The following is a description of a gene set: species: Homo sapiens from publication Menon R, Otto EA, Kokoruda A, Zhou J, Zhang Z, Yoon E, Chen YC, Troyanskaya O, Spence JR, Kretzler M, Cebrián C (PMID 30166318) Human Gene Set: MENON_FETAL_KIDNEY_0_CAP_MESENCHYME_CELLS, and this is the list of marker genes: HNRNPA1L3 (NCBI Gene Id 642659), BDP1, NBPF1, SYNE2, CCDC88A, ANP32B, CHD4, CCDC14, PTMAP2, CUX1, MCM7, TOP2A, NTRK2, ZC3H13, NASP, NR2F1, IGF2, EIF3A, ANKRD11, ENAH, TOP2B, GABPB1-AS1, H4C3, TPR, ILF3, MDK, LAMA4, RPS19P1, RBP1, PTMAP5, NCL, NUDT3, KAT6B, CENPF, NCAM1, RPS3AP6, DACH1, ATRX, PSIP1, ZKSCAN1, MEIS2, MKI67, XIST, RPS4XP6, RPS10, RBM25, SNRNP70, HMGB2, BST2, DNMT1, BAZ1B, HMGB1P6 (high mobility group box 1 pseudogene 6), USP1, RPL13AP25, ITGA8, PTMA, LYPD1, PEG10, SF3B2, PAX2, PTMS, DDX24, SUPT16H, NKTR, TIA1 (TIA1 cytotoxic granule associated RNA binding protein), BAZ2B, NOP56 (NCBI Gene Id 10528), SMC1A, GOLGA4, RIF1, SOX4, SMC4, NNAT, PPM1G, HMGB1, PTPN14, BRD3, SET (NCBI Gene Id 6418), SMC3, NR2F2, PRXL2A, NAP1L1, RSF1, DEK, H19, TUBA1A, BPTF, LUC7L3, SEPTIN6, SPEN